The following is a description of a gene set: mouse primary BMDCs were stimulated with tlr ligands and gene expression changes were profiled on Affymetrix arrays from publication Amit I, Garber M, Chevrier N, Leite AP, Donner Y, Eisenhaure T, Guttman M, Grenier JK, Li W, Zuk O, Schubert LA, Birditt B, Shay T, Goren A, Zhang X, Smith Z, Deering R, McDonald RC, Cabili M, Bernstein BE, Rinn JL, Meissner A, Root DE, Hacohen N, Regev A (PMID 19729616) Genes down-regulated in comparison of control dendritic cells (DC) at 1 h versus those stimulated with Gardiquimod (TLR7 agonist) at 1 h. Human Gene Set: GSE17721_CTRL_VS_GARDIQUIMOD_1H_BMDC_DN studied in species Homo sapiens, and this is the list of marker genes: COX5A, TMEM33, PAH, PPP1R1B, COL22A1, GMPR, CCNL1, UBC, VGLL1, IRS2, NBN, TXNL1 (NCBI Gene Id 9352), FIGNL1, C1GALT1C1, MEFV, RASGRP1, HMX2, PCID2, FTSJ1, PREPL, ARHGEF3, PRSS12, XRCC2, PCSK4, SLC22A7, RNF141 (NCBI Gene Id 50862), TUBD1, ART3, ZC3H12C, ANKRD26, FBXO31, ZFP30 (ZFP30 zinc finger protein), NCAM1, AGL, CCDC71L, NDUFA12, PPP1R15A, ATG10, ERRFI1, POLR1B, P2RY14, KLHL2, CD38, KERA, LPP-AS2, RAP2A, LIPF, PHKB, ARID5B, OLR1, NECTIN3, CETN2 (NCBI Gene Id 812), GADD45A, MAFF, NFKBIA, SECTM1, JUNB, TEX2, OR51B2 (olfactory receptor family 51 subfamily B member 2), CFAP184, TFAP2C, TOP1 (NCBI Gene Id 7150), SENP6, SPCS3, MAP3K8, TNFRSF1B, IL1RN, RNF19A, TACC3, FBXO33, PON3, EIF4E3, STX6, PDE4B (phosphodiesterase 4B), GGT5, CELA3B, SLC26A8 (NCBI Gene Id 65016), METRNL, CEMIP, CEBPZ, IPP, CLEC1B, ZFX, BCL6, ODC1, TRIP4, SH3BGR, CLEC4E, DSP, ZNG1B, PIGF, FRMD4B, LIG1, PRPSAP2, FEV (NCBI Gene Id 54738), ETS2, DAB2, TAGLN2 (transgelin 2), TLL1, SCCPDH, RBL1 (NCBI Gene Id 5933), RFC1, LSG1, TLR5, KLF13, UBR1, ORC4, CD8B (NCBI Gene Id 926), FAM50B, NOP58 (NCBI Gene Id 51602), PPM1B, SLC16A6, EN1, MC2R, CPT2, KRT17, HCAR2, STAM2, NRROS, NUP188, RBMX2, FAM227B, RCSD1, RPS2, SUPT16H, TRA2B, HPF1, EFNB3, GBP4, SVIL, SLC27A2, CCL13, WASF3, ETV6, LSM14A, B3GNT2, PTPRE, CXCL10, TAF6, FGG, FST, RMDN3, FAM162A, SLC37A1, SLC33A1, NHLH1, BMPR2, TNNI3, MAP4K5, KCNK13 (potassium two pore domain channel subfamily K member 13), BTF3L4, MECP2, CSTF1, YIPF7 (Yip1 domain family member 7), TEX14, ANXA8, INHBA, BTBD17, PNP, COL17A1, CSF1, BMP5, CTR9, OPA3, SPTSSB, RND3, IER2, CARD10, TRPS1, SRP54, NDUFAF1, PFN3, C1D, SCHIP1, HSPH1, RAB37 (RAB37, member RAS oncogene family), HMGB2, CREB3L4, CYP1A2, MAP2K1, ASPDH, CCNG2, ANGPT2, HIP1, DDHD1, DNASE2B, SCGB3A2, FBXO22, DOCK6, PIP4P2, MKNK1, PRDM1, ATF7IP2, UBR2, ZP1, ZBTB11-AS1, DUSP6, ZFP36L1, ITPR1, SOX17